The following is a description of a gene set: The series of molecular signals initiated by an extracellular purine nucleotide binding to its receptor, and ending with the regulation of a downstream cellular process, e.g. transcription. studied in species Homo sapiens Human Gene Set: GOBP_PURINERGIC_NUCLEOTIDE_RECEPTOR_SIGNALING_PATHWAY, and this is the list of marker genes: PTAFR, CNTN2, ADCY5, P2RY8, P2RY1, P2RX2, GNAI2, P2RX7, P2RY4, ADORA3, ADORA2B, P2RY13, P2RX4, ANO6, P2RX6, P2RX5, NECAB2, P2RY14, ADORA2A, P2RY2, P2RY12, CTSG (cathepsin G), P2RX3, ACP3, P2RY6, GPR171, ADA, P2RY11, GPR34, ADORA1, P2RX1, GPR87 (G protein-coupled receptor 87)